The following is a description of a gene set: from publication Cui A, Huang T, Li S, Ma A, Pérez JL, Sander C, Keskin DB, Wu CJ, Fraenkel E, Hacohen N (PMID 38057668) Genes negatively differentially expressed in cell type: γδ T cell upon treatment with cytokine: PSPN in mouse lymph nodes in vivo. species: Mus musculus Mouse Gene Set: CUI_T_CELL_GD_PERSEPHIN_RESPONSE_DN Cytokines mediate cell-cell communication in the immune system and represent important therapeutic targets. A myriad of studies have highlighted their central role in immune function, yet we lack a global view of the cellular responses of each immune cell type to each cytokine. To address this gap, the authors created the Immune Dictionary, a compendium of single-cell transcriptomic profiles of more than 17 immune cell types in response to each of 86 cytokines (>1,400 cytokine-cell type combinations) in mouse lymph nodes in vivo. A cytokine-centric view of the dictionary revealed that most cytokines induce highly cell-type-specific responses. For example, the inflammatory cytokine interleukin-1β induces distinct gene programmes in almost every cell type. A cell-type-centric view of the dictionary identified more than 66 cytokine-driven cellular polarization states across immune cell types, including previously uncharacterized states such as an interleukin-18-induced polyfunctional natural killer cell state., and this is the list of marker genes: Ddx5, Junb, Dusp1, Dusp5, Csrnp1, Fos